The following is a description of a gene set: Mouse Gene Set: GOBP_TRNA_METABOLIC_PROCESS The chemical reactions and pathways involving tRNA, transfer RNA, a class of relatively small RNA molecules responsible for mediating the insertion of amino acids into the sequence of nascent polypeptide chains during protein synthesis. Transfer RNA is characterized by the presence of many unusual minor bases, the function of which has not been completely established. studied in species Mus musculus, and this is the list of marker genes: Fars2, Tsen34, Trub2, Prorp, Mettl8, Wdr6, Nars2, Wars2, Pusl1, Trmt12, Rpp14, Pus1, Sars2, Rpp30, Sepsecs, Grsf1, Qtrt1, Tyw5, Lars1, Rars1, Mars2, Ssb (small RNA binding exonuclease protection factor La), Pus7, Trpt1, Dars2, Yrdc, Dtd2, Alkbh8, Elp5, Trmt1l, Trmt10a, Farsa, Urm1, Lrrc47, Trmt1, Tprkb, Cdkal1, Aarsd1, Mettl1, Rpusd4, Elac2, Thumpd3, Exosc7, Tars2, Kti12, Dus3l, Trmt10b, Ears2, Nsun4, Ctu1, Aars2, Kars1, Trit1, Trmt11, Adat1, Ctag2l2, Cdk5rap1, Trmo, Pop5, Trp53rkb, Dus2, Mars1, Dtwd2, Slfn8, Bcdin3d, Dtd1 (D-tyrosyl-tRNA deacylase 1), Hars1, Adat2, Rars2, B3gntl1, Rtraf, Mtfmt, Tyw1, Pus10, Gtpbp3, Rtcb, Wdr4, Clp1, Polr2f, Thg1l, Dalrd3, Adat3, Pus3, Farsb, Ctu2, Rpp21, Polr3d, Iars2, Polr3a, Cars1, Ankrd16, Cars2, Trub1, Dus4l, Nars1, Pop1, Qrsl1, Ddx1, Pop4, Vars1, Tsen2, Tsen15, Rpp38, Aars1, Trmt2b, Osgep, Osgepl1, Thumpd1, Trmt112, Hsd17b10, Tsen54, Trmu, Dus1l, Trnt1, Lsm6, Tars1, Alkbh1, Ctag2l1, Nat10, Elac1, Thumpd2, Trmt6, Tarbp1, Tyw3, Polr2e, Trdmt1, Qng1, Exosc9, Trmt13 (tRNA methyltransferase 13), Nsun6, Nsun3, Gatb, Trmt61a, Trp53rka, Elp6, Trmt9b, Elp3, Trmt10c, Tars3, Rpp40, Lcmt2, Elp4, Mettl6, Slfn2, Gatc (glutamyl-tRNA amidotransferase subunit C), Gon7 (GON7 subunit of KEOPS complex), Ptcd1, Exosc2, Elp1, Exosc8, Dtwd1, Elp2, Qars1, Gtdc1, Mocs3, Exosc3, Trmt5, Dars1, Slfn9, Ang, Iars1, Polr2l, Qtrt2, Exosc10, Trmt44, Rpp25, Hars2, Sars1, Prorsd1, Ctag2, Zbtb8os, Pars2, Yars1, Nsun2, Gars1, Pop7, Thada, Mto1, Trmt2a, Rpp25l (ribonuclease P/MRP 25 subunit-like), Wars1, Akt1, Vars2, Zcchc7, Dph3, Lars2, Ftsj1, Eprs1, Mettl2, Lage3, Yars2